Given this list of marker genes SETD4, PTH, HMGA2, SHC1, MIR27B, LEF1, MIR10A, FGFR2 (NCBI Gene Id 2263), here is a description of the gene set: A process that modulates the frequency, rate or extent of cell proliferation in the bone marrow. Human Gene Set: GOBP_REGULATION_OF_CELL_PROLIFERATION_IN_BONE_MARROW species: Homo sapiens